Given this list of marker genes RAD9A, SKIL, RPL26, PIAS4, FBH1, TP73, MTCH2, NACC2, RPS3, here is a description of the gene set: Any process that activates or increases the frequency, rate or extent of intrinsic apoptotic signaling pathway in response to DNA damage. Human Gene Set: GOBP_POSITIVE_REGULATION_OF_INTRINSIC_APOPTOTIC_SIGNALING_PATHWAY_IN_RESPONSE_TO_DNA_DAMAGE studied in species Homo sapiens